Given this list of marker genes TCEA3, YY1, ELK1, SMARCA4, ERCC1, FBXO45, POLE3, PTH, G6PD, HSP90AB1, TSPYL4, ATP1B3, B3GNT2, FOXN2, PTPN6, TWF2, LCN2, MKRN1, TFPT, GPN1, CRELD2, GALM, HSPD1, PTTG1IP, NDUFB3, ATG12, NTF3, CXCL12, ABT1, ADGRD1, RACK1, CASP12, CHMP6, SYP, RENBP, IFI30 (IFI30 lysosomal thiol reductase), FDFT1, RPSA, LSP1 (lymphocyte specific protein 1), KCNC3, IFT27, LHX8, HSD17B10, DNAJC19, HIC1, VNN2 (vanin 2), NUDT16L1, PRPF6, TSR1, TUBGCP4, RPS16, CDCA3, FOXP1, HDGF, PLXND1, FYTTD1, HCCS, MVD, RRS1, LITAF, PHTF2, MPG, DALRD3, MRPS18B, WDR82, NMU, NABP1 (nucleic acid binding protein 1), GDPD3, SAA2, CDC5L, WIPF1, LARP4B, VPS37C, VPS25, KLHL21, TAPBP, RPS27, IREB2, IDI1, FAM114A2 (NCBI Gene Id 55912), MSMO1, DIP2B, ATP5F1C, GLI1, DIO1, FSTL3, STK11IP (serine/threonine kinase 11 interacting protein), EYA2, CNTROB, MYORG, AMACR, PLA2G6, STARD3 (NCBI Gene Id 10948), ARL14EP, IMP3 (IMP U3 small nucleolar ribonucleoprotein 3), BSCL2, NPY, RBM18, MFSD1, OGFR, DUSP12, RPL6, COL4A4, GPR3, SLC17A1, TOM1 (NCBI Gene Id 10043), CITED1, RNF4, SLC39A7, MID1IP1, RSRP1, SET, VEGFC, INTS9, LTC4S (NCBI Gene Id 4056), ITGAX, DHRS7B, NPM1, FH, KRT2, SPRYD4, C2CD2 (NCBI Gene Id 54086), LIMD1, HSPA9, RPA1, GORASP2, EIF3K, TMEM205, S100A1, MAN2C1, CNPY2, SLC1A6, ETS2, CLTC, CYB5B, CP, PRPF8, NXF1, RPL7L1, ALDH2, GFER, FAP, NAB2, MRPS34, LONP2, ENTR1, MAP1LC3B, PEG10, IL13RA2, INPP5B, REEP5 (receptor accessory protein 5), CCDC93, ATP6V1B2, MRPL41, BPHL, CHD4, SGPL1, FAM20C, ARHGDIB, USP1, CINP, IFI27, F8, RPS3, ACO2, APOD, FGR, SLC26A2, LRRC59, HCK, SSU72, CLVS1, SPATS2, AKT1, PPP1R3C, RAN, PSPC1, MROH1, CDIP1, CFH (complement factor H), MAK16, ZHX1, EEF1B2, IDH3G, FPR2, SSR3, ROPN1L, TBP, NDUFB7, YIPF5, LDLR (NCBI Gene Id 3949), CAPN7, ARHGEF28, HP, EMB, MAZ (NCBI Gene Id 4150), PTGER2, MAT2A, ETF1, FGFR1OP2, here is a description of the gene set: Human Gene Set: GSE43955_10H_VS_60H_ACT_CD4_TCELL_WITH_TGFB_IL6_UP from publication Yosef N, Shalek AK, Gaublomme JT, Jin H, Lee Y, Awasthi A, Wu C, Karwacz K, Xiao S, Jorgolli M, Gennert D, Satija R, Shakya A, Lu DY, Trombetta JJ, Pillai MR, Ratcliffe PJ, Coleman ML, Bix M, Tantin D, Park H, Kuchroo VK, Regev A (PMID 23467089) Despite their enormous importance, the molecular circuits that control the differentiation of Th17 cells remain largely unknown. Recent studies have reconstructed regulatory networks in mammalian cells, but have focused on short-term responses and relied on perturbation approaches that cannot be applied to primary T cells. Here, we develop a systematic strategy – combining transcriptional profiling at high temporal resolution, novel computational algorithms, and innovative nanowire-based tools for performing gene perturbations in primary T cells – to derive and experimentally validate a temporal model of the dynamic regulatory network that controls Th17 differentiation. The network is arranged into two self-reinforcing and mutually antagonistic modules that either suppress or promote Th17 differentiation. The two modules contain 12 novel regulators with no previous implication in Th17 differentiation, which may be essential to maintain the appropriate balance of Th17 and other CD4+ T cell subsets. Overall, our study identifies and validates 39 regulatory factors that are embedded within a comprehensive temporal network and identifies novel drug targets and organizational principles for the differentiation of Th17 cells. Genes up-regulated in CD4 T helper cells Th17 treated with TGFB1 and IL6: 10h versus 60h. species: Homo sapiens